Given this list of marker genes CPM, NAXD, ZNF710, PLPP3, NUAK1, PGAP3, HPRT1, SLC38A7, GFOD1, ITPKB, MYCL, RASGRP3, SWAP70, PAPSS2, PLXND1, UROD, GBE1, EPHB2, CHD4, RFPL3, NDRG2, GPNMB, PRR5, AGO1, ASRGL1, GNPDA1, PMP22, CCDC28A, NUP85 (nucleoporin 85), OAT, OPN3, TRAK1, CD302, RMND5A, MAPK13, UBE4B, LPCAT1, RNASE4 (NCBI Gene Id 6038), CRB1, PSAP, FBP1, FAM168A, CADM1, EPN2, GGA1, CAMLG, PDGFC, UNC13B, MMD, ZMIZ1, TULP4, CBX1, BBS4, RPA1, NHERF1, ALDH9A1, CREB3L2, CALML4, ZFP36L2, ANG, LXN, HTRA1, SLC4A7, SGSM2, UBE2E3, TAL1, TAF1C, ABCG2, CD28, TM9SF1, ROR1 (NCBI Gene Id 4919), CSNK1E, ITGB5, AP1B1, TNFSF12, CTDSPL, RTN3, CACNA1I, PCLO, CDKN2AIP (CDKN2A interacting protein), MCM7, IRF4, RXRA (retinoid X receptor alpha), BMP2K, SLC36A1 (solute carrier family 36 member 1), GALNT1, REXO2, RAMP1, TYMS, TNFRSF21, MOSPD3, TESC, CCNI, THBS3, ITSN1, MMP2, DPM3, QPRT, ZNF573 (zinc finger protein 573), KDM3A, CRADD, CERK, MCM2, HTR2B, EIF3E, NFATC3, IFNGR1, FUT8, RIMS3, HOXD9, CD163, TLR5, BNC2, IQCC, ANKS1A, ZFHX3, SMS, PDHB, CRABP2, RIMS2, GRAMD4, TTC3, SERINC5, AVPI1, DNAJC9, RPL15, HS3ST2, SULF1, GADD45A, SGSM3, NPIPA1, TPD52L1, CHST7, RASA1, SF3B3, FOXO3, TLCD3A, PPT1, LTBP2, RHOBTB1, IL1R1, NUDT13, OLR1, WNK1, ARG2 (arginase 2), PASK, VSIG10, ATP5IF1, FEZ2, PTDSS2, MYOZ1, RBM41, COL6A1, PGRMC2, FOXO1, ABCC5 (ATP binding cassette subfamily C member 5), SLC16A5, FBXW2, DTNA, SLC11A1, PABPC4, EXTL2, EPAS1, ZNF8, OLFML2B, RPS6KA2 (NCBI Gene Id 6196), TIAM1, HGSNAT, VSIG4, LTA4H, ZMYND11, REV3L, MERTK, CUTA, DAB2, ARMC9, MKNK1, SESN1, CHD3, CXCR4, TRIB1, BNIP3L, DIP2C, BRD8, CD9, HAMP, DCLRE1A, SLCO2B1, RIDA, SLC7A8, PALLD, RB1CC1, SMAP1, MYOM1, KHK, FOS, DGKA, ARL3, CD14, TMEM106C, here is a description of the gene set: species: Homo sapiens Microglial cells are resident macrophages in the central nervous system (CNS) and play a pivotal role in the innate and adaptive immune responses against microbial infections. The immune functions of microglia are regulated by a milieu of cytokines including interferon (IFN)-gamma. We here performed a series of experiments to acertain the transcriptional profile of human fetal microglial cells at 1, 6, and 24 h after IFN-gamma treatment. Primary human microglial cells were either untreated or treated with 200u/ml IFN-gamma. Affymetrix U133A chips were utilized. Four different tissue samples (B18, O, W, and Y20) were analyzed at the three time points. Genes up-regulated in comparison of control microglia cells versus those 24 h after stimulation with IFNG. from publication Rock RB, Hu S, Deshpande A, Munir S, May BJ, Baker CA, Peterson PK, Kapur V (PMID 16163375) Human Gene Set: GSE1432_CTRL_VS_IFNG_24H_MICROGLIA_UP